The following is a description of a gene set: species: Homo sapiens The chemical reactions and pathways resulting in the breakdown of a nucleoside monophosphate, a compound consisting of a nucleobase linked to a deoxyribose or ribose sugar esterified with phosphate on the sugar. Human Gene Set: GOBP_NUCLEOSIDE_MONOPHOSPHATE_CATABOLIC_PROCESS, and this is the list of marker genes: PRTFDC1, NT5C2, NT5M, UPP1, GDA, XDH, AMPD3, NT5C1A, ADA, DPYD, NT5E, TYMP, DNPH1, UPB1, DPYS, UPP2, PNP, HPRT1, NT5C